Given this list of marker genes Pdk1, Pogk, Mlip, Kmt5b, Pramel21, Tlr8, Bmi1, Trpc4, Naa30 (NCBI Gene Id 75009), Zfp397, Adamts17, Treml1 (NCBI Gene Id 71326), Nrcam, Plch2, Ccdc50 (NCBI Gene Id 70600), Htra2, Brinp3, Lingo2, Elovl7, Fgf5, Sult1d1, Hacd3, Adnp, Dclk1, Kcnh8, Vav3, Pramel4, 4921517D22Rik, Zdhhc20, Rnf138, Cldn1, Pramel5, Rad21, Cacna1e, Pramel61, Cd84, Mamdc2, Col8a1, Emx2, Ica1l, Cpped1, Pdhx, Dnajb6, Bambi, Ap3m1, Ccbe1, Clint1, Glce, Ptchd4, Slco1a6, Tgm3, Dtx4, Smad4, Cep43, Foxp2, Slc2a13, Aldoart1, Drgx, Crybg3, Atp2b4, Pm20d1, Pum1, Tmem65, Calb1, Wdr48, Krt25, Gkap1, Timp3, Ahr, Chil5, here is a description of the gene set: species: Mus musculus from publication Chen Y, Wang X (PMID 31504780) Genes predicted to be targets of miRBase v22 microRNA mmu_miR_7673_5p in miRDB v6.0 with MirTarget v4 prediction scores > 80 (high confidence targets). Mouse Gene Set: MIR_7673_5P